Given this list of marker genes GDF2, SMAD5, BMP10, ACVRL1, SMAD4 (NCBI Gene Id 4089), SMAD9, SMAD1, BMPR2, ACVR2A, here is a description of the gene set: species: Homo sapiens Human Gene Set: KEGG_MEDICUS_REFERENCE_BMP9_10_SIGNALING_PATHWAY Pathway Definition from KEGG: BMP9/10 -> ((BMPR2,ACVR2A)+ACVRL1) -> (SMAD1,SMAD5,SMAD9) == SMAD4 BMP9/10 signaling pathway. Pathway ID: N01426. Pathway type: Reference. Pathway class: nt06507 TGFB signaling.